Given this list of marker genes HSPD1, MAT2A (methionine adenosyltransferase 2A), EIF4A3, MSH2, STK11, CDK7, DDX23, BUB1, CMPK1, ATP5F1B, MAP4K4, MYO18A, POLE, CDC7, HLTF, NOLC1, GTF2F2, ILF2, CDK6, PDK3, MED24, TAP2, PRKCQ, NEK2, POLR2E, CDK1, PRKCI, POLE2 (DNA polymerase epsilon 2, accessory subunit), PEX1, IGF1R, HARS1, HELZ, TTK, ABCD3, PRIM2, WEE1, MSH5, PFKFB4, DDX17, PCNA, LIG1, KIF3B, XRCC6, PRKCD, RAD54L, FES, CSNK2A1, CLK2, CAMK1, PSMC4, EPHA4, RAD51, RAD51C, DYRK3, DDX10, ORC1, KIF23, KARS1, MAPK4, IARS1, MKI67, MERTK, ERCC3, PRKX, CCT8, VARS1, NPR1, MAT1A, CDK2, CCT4, KIF2C (NCBI Gene Id 11004), RFC5, CHD4, CENPE, CDK20, TRIP13, CDK5, MAPK6, MYLK, XRCC3, COASY, GMPS, CHEK2, QARS1, ATP12A, ABCC1, NEK4, ACVR1, KHSRP, POLA1, MAPK13, PKN1, DTYMK, LIG4, XRCC5, SEPHS1, DCK, BLM, PLK1, TK1, PSMC6, EPHB2, CCT6A, PMS1, DDX1, CHEK1, STK3, MAPK14, DDX3Y, POLR2D, SMARCA2 (SWI/SNF related, matrix associated, actin dependent regulator of chromatin, subfamily a, member 2), HSPA8, POLG, GRK1, LIMK1, PEX6, HK1, RFC4, MAPKAPK3, POLR2J, RFC3, SEPHS2, TOP2A, POLD2, DYRK1A, PTK7, AK2, MCM3, CDK4, POLRMT, MYO1E, SMARCA5, RFC2, CDK8, PRP4K, MELK, POLR2K, POLR2C, RFC1, EPHB1, ABCB4, KIF11, NME2, USP14, NARS1, STK38 (NCBI Gene Id 11329), ACVR2B, CSPG4, GSS, KIF22, TIMM44, MTHFD1, CCT6B, CARS1, ABL2, PRIM1, HSPA1L, MCM6, TRAP1, CDK16, HNRNPU, RECQL4, SMC2, DDX11, LCK, NME4, MAP4K2, KIF14, IRAK1, MAP2K2, MARK3, PLK4, MAP3K8, MLH1, NME1, POLD1, DDX6 (NCBI Gene Id 1656), CSNK1E, AK4 (NCBI Gene Id 387851), SRPK2, GUCY2D, VRK2, ROR2, VRK1, DHX30, P2RX1, RUNX3, here is a description of the gene set: Response to DNA damage. species: Homo sapiens Human Gene Set: MODULE_244